Given this list of marker genes Fmo5, Akr1c18, Cyp26a1, Akr1c14, Cyp2d9, Cyp2b19, Calm3, Cyp4f15, Cyp51, Cyp2e1, Cyp2d11, Fmo2, Cyp26b1, Cyp2d34, Cyp2d26, Cyp2d40 (NCBI Gene Id 71754), Cyp4f40, Coq7, Hsp90ab1, Akr1cl, Fmo3, Cyp4x1, Nos1 (nitric oxide synthase 1, neuronal), Kmo, Fmo4, Cyp2b9, Cyp1a1, Gm4846, Cyp2d10, Mical1, Akr1c12, Fmo9, Cyp4f14, Gm4847, Akr1c6, Calm1, Mical3, Cyp2d12, Sqle (NCBI Gene Id 20775), Fmo1, Fmo6 (flavin containing monooxygenase 6), Cyp2b23, Cyp2b13, Dynll1, Akr1c13, Calm2, Akr1d1, Cyp2b10, Akr1c20, Nos2, Atp2b4, Cyp27b1, Mical2 (microtubule associated monooxygenase, calponin and LIM domain containing 2), Akr1c21, Coq6, Cyp46a1, Nos3, Akr1c19, Cyp2d22, Hsp90aa1, Akt1, Cyp4f18, here is a description of the gene set: Catalysis of an oxidation-reduction (redox) reaction in which hydrogen or electrons are transferred from NADH or NADPH and one other donor, and one atom of oxygen is incorporated into one donor. species: Mus musculus Mouse Gene Set: GOMF_OXIDOREDUCTASE_ACTIVITY_ACTING_ON_PAIRED_DONORS_WITH_INCORPORATION_OR_REDUCTION_OF_MOLECULAR_OXYGEN_NAD_P_H_AS_ONE_DONOR_AND_INCORPORATION_OF_ONE_ATOM_OF_OXYGEN